Given this list of marker genes Eppk1, B4galt1, Jaml, Cldn1, Fzd7, Wnt7a, Odam, Cxadr, Mmp12 (matrix metallopeptidase 12), Lrg1, here is a description of the gene set: species: Mus musculus Any process that activates or increases the rate or extent of epithelial cell proliferation, contributing to the restoration of integrity to a damaged tissue following an injury. Mouse Gene Set: GOBP_POSITIVE_REGULATION_OF_EPITHELIAL_CELL_PROLIFERATION_INVOLVED_IN_WOUND_HEALING